The following is a description of a gene set: species: Mus musculus Mouse Gene Set: GOCC_CYCLIN_CDK_POSITIVE_TRANSCRIPTION_ELONGATION_FACTOR_COMPLEX A transcription elongation factor complex that facilitates the transition from abortive to productive elongation by phosphorylating the CTD domain of the large subunit of DNA-directed RNA polymerase II, holoenzyme. Contains a cyclin and a cyclin-dependent protein kinase catalytic subunit., and this is the list of marker genes: Ccnt2, Cdk9, Snw1, Ccnt1, Cdk12, Rb1, Cdk13, Ccnk, Tex24, Brd4